Given this list of marker genes TFAP2A, MAD2L2, OVOL2, KDM2A, PHB1, HDAC2, BHLHE41, DACH1, MUC1, HHEX, HDAC4, SMAD7, CREB1, here is a description of the gene set: Human Gene Set: GOBP_NEGATIVE_REGULATION_OF_TRANSCRIPTION_BY_COMPETITIVE_PROMOTER_BINDING studied in species Homo sapiens Any process that stops, prevents, or reduces the frequency, rate or extent of DNA-dependent transcription using a mechanism that involves direct competition for interaction with a promoter binding site.